The following is a description of a gene set: Human Gene Set: MODULE_195 studied in species Homo sapiens Breast cancer expression clusters., and this is the list of marker genes: AVL9, SLC20A1, CTNNAL1, TYMP, RHAG, PLPBP, MYO1C, RPLP2, PSMD2, WWTR1, FADS1, VASH2, CC2D2A, SLC9A1, BMP2, PFDN4, GPER1, TRAM1, LSM14A, TXNDC16, LYN, SLC25A37, PCGF3, NF2, KLHDC10, MAPK4, EFTUD2 (NCBI Gene Id 9343), CD14, PAX8, SLC25A1, KLK6, DCTPP1, RXRB, KLF1, PICALM, CLIC4 (chloride intracellular channel 4), ALG12, GLRX, ACACB (NCBI Gene Id 32), DBNDD1, ITGA8, TGFB1, ME2, TAGLN3, SZT2, NCK1, PIF1, TRIM4, SMYD5, ADA, GJA5, FOXS1, DLK1, PTBP1, CCDC88A, ENAH, HYOU1, PHRF1, THY1, SLC25A16, PPP2R5D, ZNF217, PPP4R1, DLL1, HOXC4, SEPHS1, RPL10, LEAP2, MPPE1, ATG5, MECP2, GATM, PTMA, NPRL3 (NCBI Gene Id 8131), LAMTOR1, EID1, SARM1, MYLK2, FKBP1B, TIE1, POFUT1, NUP54, GATAD2A, CALM2, ZNF667, WWP1, OXR1, PNLIP, TNFRSF14, TMEM97, MGAT3, PTGER3, RNF4, CBY1 (NCBI Gene Id 25776), MAPT (NCBI Gene Id 8152), ELL, CRNKL1 (NCBI Gene Id 51340), THOP1, LIMCH1, SSR3, JAG1, MARCKS, SRP14, NXN, ELMO2, NNT, TSPAN18, RABIF, IFT88, RNF11, SMC1A, EXOSC4, IL1R1, CKB, GABRA2, GNAI1, ZNF423, TBC1D2B, SREBF1, PRSS3 (serine protease 3), H4C14, GC, SETDB1 (NCBI Gene Id 9869), CHORDC1, DHODH, LIMS3, CD40, NINJ1, PPP2R5C, MTMR2, CCN3, H3-3B, ROPN1, TECPR2, MKNK2, ELK1, NTRK2, CHRNA1, PLAUR, ACTA1, AUP1, KPTN, R3HDM1, PRDM1, PON3, TRAF6, CDC42SE2